The following is a description of a gene set: studied in species Homo sapiens Human Gene Set: REACTOME_CYCLIN_D_ASSOCIATED_EVENTS_IN_G1 Cyclin D associated events in G1, and this is the list of marker genes: E2F5, CDK2, PPP2R2A, CDKN1A, E2F2, CDKN1B, UBC, PPP2R3B, CDKN1C, CCNH, E2F3, CCND2, CUL1, CDK6, PPP2R1A, RBL2, RPS27A, SKP2, CCND3, RBL1, PPP2CA, JAK2, MNAT1, UBA52, CKS1B, SRC, CDKN2D, UBB, LYN, CCNE2, PPP2R1B, TFDP1, CCND1, CDK4, RB1 (RB transcriptional corepressor 1), SKP1, ABL1, TFDP2, PTK6, E2F1, CDKN2A, E2F4, CDKN2C, PPP2CB, CCNE1, CDK7, CDKN2B